Given this list of marker genes ATP11A, APAF1, HM13, SNX12, TSPO, KLHL25, NEURL1B, PTGIR (prostaglandin I2 receptor), SLC1A5, ALDH1A2, IKBKE (NCBI Gene Id 9641), ZKSCAN3, LDHA, PNISR, ASB8, PGM2, RASSF8, CFL1, MTR (NCBI Gene Id 4548), AP3B1, PIANP, CHMP1A, ALDH1B1 (NCBI Gene Id 219), PPIL1, RBM15B, PGAM1, GATM, SLC52A2, IL15RA, LIPF, LMOD1, FCGR2B, SPTBN1, CD300LF, USH1C, LSM12, UBL4A, DIP2A, PTGES2, TATDN2, JMJD8, KLHDC4, AKAP4, LSR, HJV, FBH1, TMEM183A, SEC16B, ACOT8, PAM, CUEDC2, PFKL, MVD, LIFR, MAZ, CYP2S1, MCM10, MAP1LC3A, NHEJ1, PLIN2, EPS8, EVA1B, NSMCE1 (NSE1 homolog, SMC5-SMC6 complex component), KANK3, HSD17B7, PGLS, MRGPRG, MPO (myeloperoxidase), RNF157, PLLP, DAPK1, NDUFB8, CTBP1, LZTR1, CAMK2G, CAPN5, KAZALD1, VPS4A, TRIM46, AP2S1, MRS2, KCNAB2, TMEM87B, CDKN1A, GAK, SIDT2, ITGA5, GPR137 (G protein-coupled receptor 137), FAM221B, SELE, CKS1B, PDIA4, ERI1, NACC1, E2F7, PARVB, NDUFB7, CIAO2A, MAFG, SOCS6, FAM241A, MAPKAPK3, EMILIN2, MRAS, SHTN1, FAM20C, PLAUR, AMDHD2, TMEM63C, GUSB, FLOT2, LXN, PPP3R1, TFEC, APBA3, IBTK, CTSV, HMGA1, WFDC2, PPME1, SERP1, TOLLIP, CCDC115 (coiled-coil domain containing 115), DERA, COPS7B, AP2M1, LRP12, PSMD14, ADAM9, CD93, SYT5, HDAC1, SEC63, SLC36A1, SLC13A3, TMEM165, USP2, DCTN2, GPR160, CPSF4, CORO1C, PPP1R21, HNRNPM, CCL24, PDHA1, SH3PXD2B, GALNT4, WFIKKN1, APRT, PRTN3, PGAP3, INTS3, SEBOX, CCR5, WDR83, H1-7, COMTD1, RAMP3, ATP1A1, RSL24D1 (NCBI Gene Id 51187), EIF2B2, SLC24A3, SLC2A9, HTRA3, SPP1, PPIG, IER3, DLAT, AGPAT1, IL4R, SIRT2, FKBP1B, USP5, GHDC, UBTD1, SLC39A7, FGD6, ELOVL5, SEMA6B, STAMBPL1, ACTL9, ART5, GOLT1B, CHP1, MFAP3L, RAPGEF5, DOK2, ADORA2B, OR6A2, MAP2K4, SSH3, TSSC4, ASCC1 (activating signal cointegrator 1 complex subunit 1), RNASE3, MAN2B2, CKAP4, CTDSPL, ENO1 (enolase 1), CA4, SNAI3-AS1, here is a description of the gene set: Human Gene Set: GSE8921_UNSTIM_VS_TLR1_2_STIM_MONOCYTE_24H_DN In innate immune responses, activation of Toll-like receptors (TLRs) triggers direct antimicrobial activity against intracellular bacteria, which in murine, but not human, monocytes and macrophages is mediated principally by nitric oxide. We report here that TLR activation of human macrophages up-regulated expression of the vitamin D receptor and the vitamin D-1-hydroxylase genes, leading to induction of the antimicrobial peptide cathelicidin and killing of intracellular Mycobacterium tuberculosis. We also observed that sera from African-American individuals, known to have increased susceptibility to tuberculosis, had low 25-hydroxyvitamin D and were inefficient in supporting cathelicidin messenger RNA induction. These data support a link between TLRs and vitamin D-mediated innate immunity and suggest that differences in ability of human populations to produce vitamin D may contribute to susceptibility to microbial infection. species: Homo sapiens Genes down-regulated in monocytes (24h): untreated versus M. tuberculosis 19 kDa lipopeptide. from publication Liu PT, Stenger S, Li H, Wenzel L, Tan BH, Krutzik SR, Ochoa MT, Schauber J, Wu K, Meinken C, Kamen DL, Wagner M, Bals R, Steinmeyer A, Zügel U, Gallo RL, Eisenberg D, Hewison M, Hollis BW, Adams JS, Bloom BR, Modlin RL (PMID 16497887)